The following is a description of a gene set: Human Gene Set: ZSCAN23_TARGET_GENES Genes containing one or more binding sites for (ZSCAN23) in their promoter regions (TSS -1000,+100 bp) as identified by GTRD version 20.06 ChIP-seq harmonization. studied in species Homo sapiens from publication Yevshin I, Sharipov R, Kolmykov S, Kondrakhin Y, Kolpakov F (PMID 30445619), and this is the list of marker genes: MRPL39, DRG2, MRPS31P4, MVK, LINC00933, APOO, CPSF2, ZNF629, WDR11, LINC00431, UBE2Q2P1, PPP2R5C, BCL11B, ZCCHC24, EGLN2, HEXIM1, CUL4A, TBPL1, CCDC192, MTFR2P2, TMEM255A, ASCC1 (NCBI Gene Id 51008), CCT6B, LINC01775, ENPP3, RNVU1-14, SMG7, EFCAB7, MTF2, JOSD1, WDR11-DT, LAMP1, LINC01275 (long intergenic non-protein coding RNA 1275), LY6K, TMEM242-DT, SPAG4 (NCBI Gene Id 6676), ZNF839, GADD45B (NCBI Gene Id 4616), GXYLT2, ENSG00000247416, SLC3A2, TMEM248, CEP95, ZNF335, IGF1R, MIR194-1, RNU6-2, GBA1, RNU6-859P, NCAM1, EBF1, LINC01132, MRPS31, BRWD1, TMEM259, STX6, LRP6, MMAB, SMG7-AS1, TMEM242 (NCBI Gene Id 729515), COQ3, RNVU1-15, SMARCD2, NR2F1, PCID2, FTCD, ARVCF, LINC02202, MED23, ATP6V0E1, VPS51, DNAH2, ARF6, XKR8, ANKRD54, CTNNB1, DDX5, SNHG11, CASC3, STAT6, MCM7, ITGB3BP, SLC39A3, SSBP2 (single stranded DNA binding protein 2), NDUFB1, TMEM101